The following is a description of a gene set: Human Gene Set: BUSSLINGER_ESOPHAGEAL_PROLIFERATING_BASAL_CELLS species: Homo sapiens from publication Busslinger GA, Weusten BLA, Bogte A, Begthel H, Brosens LAA, Clevers H (PMID 33691112), and this is the list of marker genes: GPNMB (NCBI Gene Id 10457), EIF4B, H2AZ1, IL1R2, EEF2, SNRPB, EEF1A1, LAMB3, NAP1L1, TKT, GPX4, COL17A1, TUBA1B, STMN1, HMGB1, HMGB2, RRM2, HOPX, TK1, RPL5, SLC3A2, HNRNPC, NUSAP1, DSC3, KRT14, RPS3, ANP32B, B2M, SLC7A5, RPL10, HNRNPA1, RPL18A, SMC4, NUCKS1 (NCBI Gene Id 64710), ENO1, DST, KRT5, MCM7, ASS1 (NCBI Gene Id 445), H4C3 (H4 clustered histone 3), TUBB, FBL, EEF1B2, NFIC, CXCL14, PRC1, NCL, RPL4, KRT19, ASPM, KRT15, MKI67, RPL15, ARL6IP1, YBX1, PTMA, SYNE2, MT2A, CENPF, CD81, CAV1 (NCBI Gene Id 857), RPL13A, RPS5, RPL10A, ITGA6, IFITM3, HNRNPA2B1, SLC7A1, ATP1B3, TOP2A